Given this list of marker genes TMEM97, UNC13B, CELF4, PPP2R5E, ATP1B1, ZIC4, FBXO11, CLEC2A, HPN, HOXA11, ZFHX3, MCTP2, NOS3, NAV3, EGFR (NCBI Gene Id 1956), USP7, NFATC2, ATPAF2, GORAB, BPIFA1 (BPI fold containing family A member 1), NGF (nerve growth factor), SLCO2A1, RBP4 (NCBI Gene Id 5950), CLDN14, CCDC71L, ETV1, ESR1, FXYD5 (NCBI Gene Id 53827), ID2, PTP4A1, EYA1, GABRG2, CSRNP3, EHMT2, PAIP2, NIPAL2, FOXP2, RCAN1, NFATC1, BPIFB1, ODF2 (NCBI Gene Id 4957), HAPLN1 (hyaluronan and proteoglycan link protein 1), DQX1, OGT, PAX2 (NCBI Gene Id 5076), TECTA, INPP5A, MAST4, ILRUN, CCDC80, ZBTB37, NFIB, ATP10D, ESRP2, ZNF436, MAB21L2, ALDH1A2, LRP1, PCMTD2, SLC11A2, CALD1, TRAT1, PPP1R1B, TSPAN6, ZNF423, PTGR3, ANKRD28, IMPDH2, NOVA1, KLF5 (KLF transcription factor 5), ACACA, MIP, MITF (NCBI Gene Id 7487), HOXD3, BMP5, SCUBE3, DMXL1, TRPS1, PITX1, RFX3, CAB39L, C1orf198, HAS2, GGA2, CREB5, PUM2, DHRS3, SMIM11, METTL8, PTPRG, HOXA2, C4orf19, GPR85, RPP21, GRIA1, ZIC2, GCM1, BPIFA2, DPF3, SWAP70, BCL11A, SLC31A2, HOXC4, AP1G2, F13A1, HOXC6, PDGFRL, CALM2, BACH1, PRSS35, ASIC2 (NCBI Gene Id 729787), HOXA7, ZIC1, C16orf87, CFL2, SLC38A3 (solute carrier family 38 member 3), DCX (doublecortin), PTMS, FOXP1, SERPIND1, TRIM47, LINC03124, FBLN5, RGS3, DMD, KCTD6, HNF1A, SPAG9, NTRK2, MAP2K6, MSTN, BOK, RXFP4, DCAF17, GID4, CBLL2, MARCO, PHEX, NDP, UNC50, LMO4, ZNF654, PTPRCAP, DDX46, REPS2, STX6, IL23A, TANK, PROK2, SLC6A9, TGM5, FHIT (fragile histidine triad diadenosine triphosphatase), CNIH2, AQP5, PCYT1B, here is a description of the gene set: Genes having at least one occurrence of the highly conserved motif M107 RTTTNNNYTGGM in the regions spanning 4 kb centered on their transcription starting sites. The motif does not match any known transcription factor binding site. Human Gene Set: RTTTNNNYTGGM_UNKNOWN from publication Xie X, Lu J, Kulbokas EJ, Golub TR, Mootha V, Lindblad-Toh K, Lander ES, Kellis M (PMID 15735639) species: Homo sapiens Comprehensive identification of all functional elements encoded in the human genome is a fundamental need in biomedical research. Here, we present a comparative analysis of the human, mouse, rat and dog genomes to create a systematic catalogue of common regulatory motifs in promoters and 3' untranslated regions (3' UTRs). The promoter analysis yields 174 candidate motifs, including most previously known transcription-factor binding sites and 105 new motifs. The 3'-UTR analysis yields 106 motifs likely to be involved in post-transcriptional regulation. Nearly one-half are associated with microRNAs (miRNAs), leading to the discovery of many new miRNA genes and their likely target genes. Our results suggest that previous estimates of the number of human miRNA genes were low, and that miRNAs regulate at least 20% of human genes. The overall results provide a systematic view of gene regulation in the human, which will be refined as additional mammalian genomes become available.